Given this list of marker genes SMARCE1, COL3A1 (NCBI Gene Id 1281), TRAF7, TERT, SMARCB1, UGT1A1, AKT3, MAFB, ADA2, CHN1, NF2, CDH23, MTOR, PIK3CA, SMO, AIP, SUFU, PLEC, MEN1, ANGPTL6, THSD1, BAP1, ENG, TRPV4, SALL4, TGFBR3 (transforming growth factor beta receptor 3), AKT1, MYMK, PDGFB, here is a description of the gene set: Human Gene Set: HP_OCULOMOTOR_NERVE_PALSY studied in species Homo sapiens Reduced ability to control the movement of the eye associated with damage to the third cranial nerve (the oculomotor nerve). Oculomotor nerve palsy